The following is a description of a gene set: Reactome Pathway: Defective MTR causes HMAG species: Homo sapiens part of: Defects in cobalamin (B12) metabolism Defects in MTR cause methylcobalamin deficiency type G (cblG; MIM:250940), an autosomal recessive inherited disease that causes mental retardation, macrocytic anemia, and homocystinuria., and this is the list of marker genes: MTRR, MTR